The following is a description of a gene set: Any process that stops, prevents or reduces the frequency, rate or extent of blood vessel endothelial cell proliferation involved in sprouting angiogenesis. species: Mus musculus Mouse Gene Set: GOBP_NEGATIVE_REGULATION_OF_BLOOD_VESSEL_ENDOTHELIAL_CELL_PROLIFERATION_INVOLVED_IN_SPROUTING_ANGIOGENESIS, and this is the list of marker genes: Ngfr, Dll4, Thbs1, Mmrn2, Il12a, Il12b, Pdcd10